Given this list of marker genes Gsta4, Bmp8a, Plekhg1, A830018L16Rik, Prlr, Rad51b, Slc25a13, Tnrc6a, Runx1t1, Trpm1, Wdr46 (WD repeat domain 46), Notch4, Zfp963, Prss22, Il4i1, Eif3j2, Bnc1, Ankrd54, Fam53b, Kdm4a, Pcmt1, Jade1, Eif3j1, Asb7, Tmem175, Ap3s1, Vwf, Grm1, Arrb1, Borcs8, Coq4, Dsg1c, Kcnj13, Myof, Icosl, Ccdc167, Dbx2, Pms2, Nfatc3 (nuclear factor of activated T cells, cytoplasmic, calcineurin dependent 3), Slc30a7, here is a description of the gene set: from publication Chen Y, Wang X (PMID 31504780) species: Mus musculus Mouse Gene Set: MIR_134_3P Genes predicted to be targets of miRBase v22 microRNA mmu_miR_134_3p in miRDB v6.0 with MirTarget v4 prediction scores > 80 (high confidence targets).